The following is a description of a gene set: An abnormality of coagulation related to a decreased concentration of vitamin K-dependent protein C. Protein C is activated to protein Ca by thrombin bound to thrombomodulin. Activated protein C degrades factors VIIIa and Va. Reduced protein C activity studied in species Homo sapiens Human Gene Set: HP_REDUCED_PROTEIN_C_ACTIVITY, and this is the list of marker genes: ALG8, ALG6, STX5, MPI, GGCX, DPM1, B4GALT1, NGLY1, PROC, ALG12